Given this list of marker genes RMI1, CCT8, GTPBP8, ST8SIA4, SLC2A1, TOR1A, LIMA1, ACTL6A, CSTF1, ALDOA, PSMD14, UMPS, PDIA5, SLC25A32, CHAF1A, DUSP14, COL6A3, SLC25A44, RBM28, IER3, CSF2, MRPL15, FASTKD3, SLC25A17, FIP1L1, CDC7, MAMLD1, MYG1, RFC3, CMAHP, ABCF1, EEF1E1, ERGIC2, PLAGL2, PSMC2, RNF34, MED27, ELAVL1, SNRNP40, HIGD1A, PCNA, NDUFS3, VDR (NCBI Gene Id 7421), DDX18, ACSL3, BLTP3B, NDUFAB1, SEPHS1, FOCAD, ERAL1, GNG4, RBM23, TMEM165, COX7B, BATF3, PHLPP2, NDUFV2, RFC4, STOML2, CCT2, PSMD1 (proteasome 26S subunit, non-ATPase 1), IRF4, C1D, CCT7, MAD2L1, BMS1, E2F6, HPRT1, GMNN, NUP153, SEC24D, SUPT16H, GOT1, KHSRP, ENOPH1, SLCO4A1, MLH1, BET1, NT5DC2, AHSA1 (activator of HSP90 ATPase activity 1), GCN1, PPP1R8, UCHL1, DFFA, U2AF1, OGFOD1, CCR5, RACGAP1, CCNE1, TOR4A, IMPDH2, FAR2, SHMT2, PLAA, MRPL19, ARSB, DIABLO, PSMA3, DNA2, CSNK2A1, BAG2, TMCO1, BAZ1B, DAG1, PDCD6, ETNK1, PRC1, RAD50, CCNB1, PSMD11 (proteasome 26S subunit, non-ATPase 11), CLUH, RTCB, LAG3, CDC20, ATOX1, TFRC, WDR18, ATP2A2, MTCH2, EIF2S2, CHD4, DVL3, EIF2S1, SNRPE, SDC4, PICALM, COX17, TMEM147, PRPF4, EIF2B3, TBRG4, P4HA2, CHAF1B, GTF2A2, SLC5A3, XPOT, FXN, CACYBP (NCBI Gene Id 27101), MCM7, EOLA1, TMEM33, GLRX2 (glutaredoxin 2), TPI1, GABPB1, STRAP (serine/threonine kinase receptor associated protein), DDX10, DPAGT1, TYMS, FAH, KIF3A, KCNN4, MRPL33, HMBS, ZKSCAN4, UCHL3, HSPE1, RAD51, RAN, SAC3D1, MRPL22, AGO2, CAMK1, ELOVL6, SAMM50, IGFLR1, TRAPPC2L, MRPL23, SDF2, NT5DC3, MTHFD1, ESRRA, DHDDS, HMGCR, TGS1, ZNF593, RANBP1, SART3, ERCC1, CCDC86, SFXN1, MCTP2, GTF2H1, NSDHL, POLR3K, NOLC1, CISH, FEN1, CCDC51 (NCBI Gene Id 79714), H2BC12L, ERLIN1, MYCBP, PSMA1, NARS1, RANGAP1, CCT6A, IVD, CSTF2, PREP, ATP8B4, here is a description of the gene set: Immune cell-specific expression is one indication of the importance of a gene's role in the immune response. In order to identify such patterns, we set out to broadly profile gene expression in a variety of immune cells. from publication Abbas AR, Baldwin D, Ma Y, Ouyang W, Gurney A, Martin F, Fong S, van Lookeren Campagne M, Godowski P, Williams PM, Chan AC, Clark HF (PMID 15789058) species: Homo sapiens Human Gene Set: GSE22886_NAIVE_CD4_TCELL_VS_12H_ACT_TH1_DN Genes down-regulated in comparison of naive CD4 T cells versus stimulated CD4 Th1 cells at 12 h.